Given this list of marker genes ABCG1, ZNF467, RETREG1 (NCBI Gene Id 96119), DGKD, PES1, KCNQ1, NHERF1, GRHPR, ACSL4, MYH11, ATP9A (ATPase phospholipid transporting 9A (putative)), BTN2A2, HEG1, RPL4, ARID3B, PDE2A, SVIL, RARA, UTP11, ITGA5, TMEM243, EIF6, RUNX1T1, DENND3 (DENN domain containing 3), UBE2L3, IFITM1 (interferon induced transmembrane protein 1), LDHA, FOXO3, COL14A1, POU6F1, RYR1, FCER2, TERF2, HGF, SPTAN1, AQP4, HSPB1, INSL3, CD34, ESYT1, RPL28, ABCD1, CERS2, PDE4D, OAZ3, PHB2, TCF7, PPM1F, PPP1R16B, FLAD1, FAM171A1, ADAR, ZNF135, GAD1, PSG6, ABCG5, XPNPEP1, MLNR, TSPAN7, CHST7, PRAME, LTBP4, ELOC, QARS1, SLC9A2, FXYD5, SCRN1, DDO, LDLR, TUFM, HPCAL1, PI4K2A, NBL1, PCSK6, PLEKHO1 (pleckstrin homology domain containing O1), GNAQ, VAMP5, PYGB, CAMKK2, PDE4B, RNFT2, EPHB2, DUSP5, GJB3, PLEKHG3, CD7, FHL1, SIPA1L1 (NCBI Gene Id 283567), EEF1D, DSC1, GUCY1B1, SPTBN2, EHD1, LRRN2, HLA-DQA1, SERPINF1, PSMA6, GPR6, TRPM4, SUN2, GPM6B, PDX1, MAP4K1, DEFA4, NIT2, ARL4C, GDI2, PABPC4, SNRK, DRG1, ST14, HSPG2, TTC21B, MRC1, CS, PMAIP1, EPHX2, PRKAR1AP1, CD200, TNFRSF25, FGFR1, PLCG1, NFYC, MEF2A, SOCS3, KATNB1, LAX1, TMPRSS2, PLCB4, NPR3, TGFBR2, CSNK2A2, GPI, MOB1A, WHRN, HOXC4, BCAT1, RRP9, LRP4, LAMP5, EIF3D, ATP10A, EIF3F, COPS5, EMC1, MPHOSPH6, RAB11A, RERE, CARM1, ACLY, RETN, CNN2, FHOD3, CAPN3, RAB4A (RAB4A, member RAS oncogene family), UXT, CLXN, TPPP3, HOOK2, RNF130 (NCBI Gene Id 55819), LPAR6, here is a description of the gene set: from publication Mullighan CG, Kennedy A, Zhou X, Radtke I, Phillips LA, Shurtleff SA, Downing JR (PMID 17597811) Somatic mutations in nucleophosmin (NPM1) occur in approximately 35% of adult acute myeloid leukemia (AML). To assess the frequency of NPM1 mutations in pediatric AML, we sequenced NPM1 in the diagnostic blasts from 93 pediatric AML patients. Six cases harbored NPM1 mutations, with each case lacking common cytogenetic abnormalities. To explore the phenotype of the AMLs with NPM1 mutations, gene expression profiles were obtained using Affymetrix U133A microarrays. NPM1 mutations were associated with increased expression of multiple homeobox genes including HOXA9, A10, B2, B6 and MEIS1. As dysregulated homeobox gene expression is also a feature of MLL-rearranged leukemia, the gene expression signatures of NPM1-mutated and MLL-rearranged leukemias were compared. Significant differences were identified between these leukemia subtypes including the expression of different HOX genes, with NPM1-mutated AML showing higher levels of expression of HOXB2, B3, B6 and D4. These results confirm recent reports of perturbed HOX expression in NPM1-mutated adult AML, and provide the first evidence that the NPM1-mutated signature is distinct from MLL-rearranged AML. These findings suggest that mutated NPM1 leads to dysregulated HOX expression via a different mechanism than MLL rearrangement. studied in species Homo sapiens Human Gene Set: MULLIGHAN_NPM1_SIGNATURE_3_DN The 'NPM1 signature 3': genes down-regulated in pediatric AML (acute myeloid leukemia) with mutated NPM1 compared to the AML cases with intact NPM1 and MLL.